Given this list of marker genes Prkaa2, Prkag1, Foxk1, Entpd5, Enpp1, Eif6, Aldoa, Entpd1, Entpd7, Pkm, Prkag2, Hif1a, Trex1, Fhit (NCBI Gene Id 14198), Nt5m, Git1, Hk3, Aldob, Gck, Slc4a4, Hk1, Entpd4, Nt5c3, Prkag3, Sarm1, Dut, Nnmt, Eno4, Itpa, Pgk2, Hprt1, Tigar, Eno2, Pde8a, Mtor (mechanistic target of rapamycin kinase), Upp2, Pfkp, Nudt9, Ddit4, Ncf2, Pklr, Nudt4, Aldoc, Slc2a6, Src, Mlst8, Gpi1, Ppp2ca, Ogdh, Ins2, Bpgm, Dctpp1, Eno1, Hdac4, Pgk1, Stat3, Ucp2, Gale (NCBI Gene Id 74246), Dnph1, Insr, Kat2b, Nt5c1b, Dpys, Nt5c2, Khk, Col6a1, Bcl2l13, Pnp, Ppara (NCBI Gene Id 399624), Slc29a1, Pfkfb2, Ada, Dhtkd1, Il3, Pde2a, Trim63, Gapdhrt, Gapdhs, Hkdc1, Ier3, Ogt, Pde9a, Nudt16, Mtch2, Uchl1, Enpp5, Cnp, Gda, Ncf1, Slc4a1, Jmjd8, Cda, Pde7a, Ins1, Pgam2, Rptor, Galk1, Upp1, Esrrb, Pfkfb1, Nupr1, Urad (ureidoimidazoline (2-oxo-4-hydroxy-4-carboxy-5) decarboxylase), Prkaa1, Upb1, Pde10a, Arnt, Dpyd (NCBI Gene Id 99586), Pde1a, Mlx, Ampd3, Gapdhrt2, Pde4a, Mpi, Arl2, Sik2, Nudt10, Nt5e, Prkaca, Igf1, Pfkl, Gmpr2, Nudt13, P2rx7, Gapdh, Tkfc, Adpgk, Nudt18, Prxl2c, Nudt11, Vcp, Sirt6, Art2a, Hk2, Mlxipl, Entpd4b, Lipa, Actn3, Myc, Fbp1, Nudt3, Zbtb20 (zinc finger and BTB domain containing 20), Eno1b, Pde7b, Pde5a, Pde8b, Nt5c, Pde4d, Parp14 (NCBI Gene Id 72239), Pde4c, Htr2a, Uox, Ep300 (E1A binding protein p300), Xdh, Art2b, Ifng, Nudt17, Aox1, Ncor1, Mfsd8, Psen1, Dera, Ppargc1a, Pgam1, Aldoart1, Flcn, Foxk2, Eno3, Pfkfb3, Galt, Hint1, App, Pfkm, Zbtb7a, Samhd1, Tpi1, Cbfa2t3, Nt5c1a, Fkrp, Nudt12, Nudt15, Tymp, Myog, Urah, Aldoart2, Gpd1, here is a description of the gene set: Mouse Gene Set: GOBP_NUCLEOTIDE_CATABOLIC_PROCESS The chemical reactions and pathways resulting in the breakdown of nucleotides, any nucleoside that is esterified with (ortho)phosphate or an oligophosphate at any hydroxyl group on the glycose moiety; may be mono-, di- or triphosphate; this definition includes cyclic-nucleotides (nucleoside cyclic phosphates). studied in species Mus musculus